Given this list of marker genes PTPN14, CDC42EP5, CYTH1, COTL1, ACTG2, KRT18, RUNX1, DKK3, OGFR, S100A6, SPIN1, GALNT2, AK2, GFRA1, IL13RA1, BHLHE40, LPL, HES1, STAT5B, ETS2, EPAS1, CP, CLIC1, F3, F2R, TGM2, ACAT1, GALC, FOXP1, BPGM, CA8, MMP2, IER5, SFPQ, MARCKSL1, SLC2A1, SNTB2, BMP1, NOTCH4, KDR, FABP3, MAPK8, GJA1 (NCBI Gene Id 7953), EHD1, CCN1, CAP1, ATP1A1, ACADVL, CRK, COL7A1, SIRPA, FZD6, CALD1, WEE1, FN1, SERPINB5, COPS2, MAL, TGFBR1, EPB41L2, PIAS3, VCAN, TJP2, ST14, UTRN, G0S2, LIPG, CEACAM1, RAD23A, TIMP2, EGR2, COMT, FHL1, FZD4, TLE3, ADAM10, CSNK2A1, CD14, CYB561, MEF2C, QKI, CLU, COL8A1, DLAT, CITED1, RPS6KA3, GALNT3, UBE2D1, CNN1, GUSB, AKT1, HTRA1, GRB10, PLAT, BASP1, RPL27A, COL16A1, DUSP16, TGIF1, MAPK14, NET1, NRIP1, PCOLCE, CHD4, CEMIP2, CYB5R3 (NCBI Gene Id 1727), ECM1, SIAH2, CCNK, PICALM, RAB17, TNS1, SRSF2, DPYSL3, FOXA1, APLP2, LTF, SOX9, SOCS2, CRIM1, DNM2, WNT5A, PDGFC, PTK2B, FMR1, ETS1, TNFAIP6, EXTL3, TPP2, VEGFA, IER3, MFGE8, TAGLN, MMP14, CAPG, NFIC, HK1, PTPRK, JAG1, ARL4A, TPM2, TUBA4A, ACAA2, CYC1, HDLBP, EGLN1, LASP1, SMARCA1, PLOD2, CPD, NFIB, TNC, PRKACB (NCBI Gene Id 5567), VASN, ITGAV, CDH11, CNN3, TPSB2, ACTA2, RAB5C, HAS2, CDKN1A, TSC22D1, JPT1, CDKN2B, GSN, FABP5, HSPG2, here is a description of the gene set: species: Mus musculus from publication McBryan J, Howlin J, Kenny PA, Shioda T, Martin F (PMID 17486082) Pubertal genes up-regulated by TGFB1. Expression microarray analysis identified over genes regulated during puberty in the mouse mammary gland. Most prominent were genes whose expression increased in parallel with pubertal development and remained high thereafter. Members of the Wnt, transforming growth factor-beta and oestrogen-signalling pathways were significantly overrepresented. Comparison to expression data from CITED1 knockout mice identified a subset of oestrogen-responsive genes displaying altered expression in the absence of CITED1. Included in this subset are stanniocalcin2 (Stc2) and amphiregulin (Areg). Chromatin immunoprecipitation revealed that ERalpha binds to oestrogen response elements in both the Stc2 and Areg genes in the mammary gland during puberty. Additionally, CITED1 and ERalpha localize to the same epithelial cells of the pubertal mammary gland, supporting a role for interaction of these two proteins during normal development. In a human breast cancer data set, expression of Stc2, Areg and CITED1 parallel that of ERalpha. Similar to ERalpha, CITED1 expression correlates with good outcome in breast cancer, implying that potential maintenance of the ERalpha-CITED1 co-regulated signalling pathway in breast tumours can indicate good prognosis. Human Gene Set: MCBRYAN_PUBERTAL_TGFB1_TARGETS_UP